Given this list of marker genes AKR1E2, FAM241A, QRICH1, XDH, TJP2, ADAM8, LBP, THBS1, TLR1, VEGFA, SNHG6, CTSK, C1QB, CRIPT, UCHL1, EFHD2, LIN7C, ARG1, SOAT1, PDXDC1, CHIA, PKDCC, CD24, ANG, HS6ST1, F10, PRDX2, MYO1F, ERO1A, ITGB3, HILPDA, RIMBP2, AK4, FAM199X, HSPA1A, FBLIM1, BNIP3, C1QTNF12, EGLN3, ARSK, C5orf34, COL20A1, FAM177A1, F7, ATP6V0D2, FLRT2, SCD (stearoyl-CoA desaturase), IGF2R, ANKRD37, CBLB, ATG4D, CYTIP, HLA-B (major histocompatibility complex, class I, B), RRAS2, IGHM, BST1, TMEM267, SLC2A1, HSPA1B, RPGRIP1, ALDOC, CD300LD, MFGE8, C1QC, MGST2 (NCBI Gene Id 4258, microsomal glutathione S-transferase 2), GDF15, SH2B2, TULP4, PPP1R3E, CD300C, CD5L, GASK1B, LRRC27, PADI4, IL18BP, PTGER2, PROCR, RGCC, MCOLN3, PINK1, GPRC5B, AHNAK2, here is a description of the gene set: Down-regulated genes distinguishing between M1 (pro-inflammatory) and M2 (anti-inflammatory) macrophage subtypes. species: Mus musculus Human Gene Set: COATES_MACROPHAGE_M1_VS_M2_DN In addition to the directly mutagenic effects of energy deposition in DNA, ionizing radiation is associated with a variety of untargeted and delayed effects that result in ongoing bone marrow damage. Delayed effects are genotype dependent with CBA/Ca mice, but not C57BL/6 mice, susceptible to the induction of damage and also radiation-induced acute myeloid leukemia. Because macrophages are a potential source of ongoing damaging signals, we have determined their gene expression profiles and we show that bone marrow-derived macrophages show widely different intrinsic expression patterns. The profiles classify macrophages derived from CBA/Ca mice as M1-like (pro-inflammatory) and those from C57BL/6 mice as M2-like (anti-inflammatory); measurements of NOS2 and arginase activity in normal bone marrow macrophages confirm these findings. After irradiation in vivo, but not in vitro, C57BL/6 macrophages show a reduction in NOS2 and an increase in arginase activities, indicating a further M2 response, whereas CBA/Ca macrophages retain an M1 phenotype. Activation of specific signal transducer and activator of transcription signaling pathways in irradiated hemopoietic tissues supports these observations. The data indicate that macrophage activation is not a direct effect of radiation but a tissue response, secondary to the initial radiation exposure, and have important implications for understanding genotype-dependent responses and the mechanisms of the hemotoxic and leukemogenic consequences of radiation exposure. from publication Coates PJ, Rundle JK, Lorimore SA, Wright EG (PMID 18199539)